Given this list of marker genes ANXA5, MDFI, NCK2, ITGAV, HMGA1, STK25, TUBB6, DENR, ARPC1B, HILPDA, KPNB1, PLCE1, CD63, CAP1, ITGB1, MAPK3, FGD6, CKS2, here is a description of the gene set: Selected up-regulated MET target genes from a classifier of hepatocellular carcinoma (HCC) cases; associated with poor survival. from publication Kaposi-Novak P, Lee JS, Gòmez-Quiroz L, Coulouarn C, Factor VM, Thorgeirsson SS (PMID 16710476) Identification of specific gene expression signatures characteristic of oncogenic pathways is an important step toward molecular classification of human malignancies. Aberrant activation of the Met signaling pathway is frequently associated with tumor progression and metastasis. In this study, we defined the Met-dependent gene expression signature using global gene expression profiling of WT and Met-deficient primary mouse hepatocytes. Newly identified transcriptional targets of the Met pathway included genes involved in the regulation of oxidative stress responses as well as cell motility, cytoskeletal organization, and angiogenesis. To assess the importance of a Met-regulated gene expression signature, a comparative functional genomic approach was applied to 242 human hepatocellular carcinomas (HCCs) and 7 metastatic liver lesions. Cluster analysis revealed that a subset of human HCCs and all liver metastases shared the Met-induced expression signature. Furthermore, the presence of the Met signature showed significant correlation with increased vascular invasion rate and microvessel density as well as with decreased mean survival time of HCC patients. We conclude that the genetically defined gene expression signatures in combination with comparative functional genomics constitute an attractive paradigm for defining both the function of oncogenic pathways and the clinically relevant subgroups of human cancers. studied in species Homo sapiens Human Gene Set: KAPOSI_LIVER_CANCER_MET_UP